Given this list of marker genes Gria2, Cacna2d2 (NCBI Gene Id 56808), Foxp3, Anp32e, Rex2, Tcf12, Zfp600, Zbtb34, Nol4, Trdmt1, Elavl2, Vangl1, Rffl, Cyp2e1, Kmt5b, Dcaf12, Thtpa, Socs6, Psd, Dennd6a, Jazf1, Atp8a1, 9430038I01Rik, Crebzf, Ptbp1, Ell3, Npc2, Sema3b, U2af2, Ifnar1, Rrbp1, Pitpna, Guf1, Zfp980, Chic1, Msh5, here is a description of the gene set: species: Mus musculus from publication Chen Y, Wang X (PMID 31504780) Genes predicted to be targets of miRBase v22 microRNA mmu_miR_6898_5p in miRDB v6.0 with MirTarget v4 prediction scores > 80 (high confidence targets). Mouse Gene Set: MIR_6898_5P